The following is a description of a gene set: species: Mus musculus The aggregation, arrangement and bonding together of an integrin, a heterodimeric adhesion receptor formed by the non-covalent association of particular alpha and beta subunits, that lead to the increased affinity of the integrin for its extracellular ligands. Mouse Gene Set: GOBP_INTEGRIN_ACTIVATION, and this is the list of marker genes: Mzb1, Cx3cl1, Fermt3, Foxc2, Tln1, Plek (pleckstrin), Selp, Ptger4, Cd24a, Fblim1 (filamin binding LIM protein 1), Lrp12, Fermt1, Col16a1, Jam3, Pcsk5, Cxcl13, P2ry12, Rap1b, Fermt2, Kif14, Cxcl12, Fn1, Krit1, Piezo1, Rasip1, Skap1 (src family associated phosphoprotein 1), Cdh17, Itgb1bp1, Farp2